The following is a description of a gene set: Mouse Gene Set: GOBP_NEGATIVE_REGULATION_OF_SEROTONIN_SECRETION Any process that stops, prevents, or reduces the frequency, rate or extent of the regulated release of serotonin. studied in species Mus musculus, and this is the list of marker genes: Htr7, Htr1b, Cd300a, Cnr1, Hrh3 (NCBI Gene Id 99296), Maob